The following is a description of a gene set: Any process involved directly in viral genome replication, including viral nucleotide metabolism. species: Mus musculus Mouse Gene Set: GOBP_VIRAL_GENOME_REPLICATION, and this is the list of marker genes: Ifi213 (interferon activated gene 213), Notch1, Mir93, Ifi203-ps, Ccnk, Shfl, Pik3c3, Vapb, Oas3, Ifi203, Tmem39a, Nucks1, Larp1, Ddx3x, Bcl2, Tbc1d20, Ifitm1, Znfx1, Plscr1, Mphosph8, Rad23a, Cnot7, Vapa, Tasor, Rsad2, Gas6, Mx2, Ppie, Fmr1, Oas1c, Trim38, Srpk1, N4bp1, Ifi214, Zc3hav1, Prox1, Adarb1 (adenosine deaminase, RNA-specific, B1), Ythdc2, Aicda, Gm11772, Ppih, Atg16l2, Apobec3, Nr5a2, Dicer1, Smc6, Tarbp2, Hspa8, Zfyve1, Slpi, Isg20, Kpna6, Ddx56, Eef1a1, Bst2, Ifitm2, Mir24-1, Ccl5, Oas2, Ppid, Oasl1, Banf1, Ifi209, Morc2a, Ifnb1, Eif2ak2, Eif2ak4, D1Pas1, Pde12, Tnf, Ccl8, Vcp (valosin containing protein, NCBI Gene Id 269523), Ifi208 (NCBI Gene Id 100033459), Adar, Pkn2, Mndal, Pcbp2, Stau1, Trim28, Hmga2, Ppihl, Oas1f, Atg7, Fkbp6, Ilf3, Mavs, Mir378a, Ifnl3, Atg16l1, Srpk2, Fam111a, Grk2, Fbxl2, Ltf, Isg15, Ddx5, Oasl2, Morc2b, Oas1d, Mir24-2, Zfp809, Ifi207, Ifih1, Setdb1, Ifitm6, Ppia, Stom (NCBI Gene Id 227754), Oas1a, Top2a, Atg5, Ifitm3, Top2b, Phb1, Hacd3, Pcbp1, Slc38a8, Prkn, Rnasel, Smc5, Tmem41b, Gbp7, Ifi206, Ddb1, Oas1e, Oas1g, Inpp5k, Oas1h, Ppib, Smarcb1, Trim6, Oas1b, Zc3h12a, Ifitm7 (interferon induced transmembrane protein 7)